Given this list of marker genes DST, MGP, CELSR1, AK5, ANPEP, DACH1, SSH3, NPY2R, IGFBP2, BST2, PDGFA, STC1, PPIP5K1, ACADSB (NCBI Gene Id 654185), ARMT1, PDZK1, HMGCS2, CELSR2, H2AC6, MYB, ZDHHC11, MAPT, ERBB4, CNN1, CA12, INPP4B, HBB, CRLF1, LTBP4, SERPINA5, SLC39A6, RABGAP1, SYMPK, LAMB3, GRP, KCTD2, FGF2, IGSF1, KDM4B, CPB1, FRMD4A, DNAJC12, WIF1 (WNT inhibitory factor 1), HBA1, ESR1, ANKH, IGF1R, PLAT, NEDD4L, CHI3L1 (chitinase 3 like 1, NCBI Gene Id 7836), COL4A5, KLK10, KRT5, TAPT1, SEZ6L2, FBXO2, ALDH4A1, CACNA1D, SLC27A6, CDK10, LGALS4, MPPED2 (NCBI Gene Id 744), WNT5A, PEX6, KRT6B, IFT140, DKK3, LTF (lactotransferrin), WFDC2, ACSM1, PTN, FRZB, MSX2, PKP1, SDC4, GFRA1, TRA2A, CYP1A1, GSTT1, TIMM44, CD59, RPL29P17 (NCBI Gene Id 729105), SLC25A37, KRT17, MYLK, ECE1, ARHGEF5, CLEC3B, CAPN3, TPM2, CLMN, EREG, GOLGA2P5, STC2, SYT17, FABP7, RABEP1, FLNB, AZGP1, TMEM101, CCDC170, TESC, NPY1R, SYNM, NQO1, EXOC7, EDN3, IL17RB, PPP1R3C, FGFR3, MATN2, OXTR (NCBI Gene Id 5021), GATA3, PIK3R1 (NCBI Gene Id 5295), SERPINA3, MIA, GRIA2, UGT2B11 (NCBI Gene Id 10720), CYP4B1, TDRD12, SAA1, XYLT2, VTCN1, TF, CITED1 (Cbp/p300 interacting transactivator with Glu/Asp rich carboxy-terminal domain 1), ITGA7, DCT, LTBP3 (latent transforming growth factor beta binding protein 3), CD151, ITPR1, BMP5, SCUBE2, PGGHG, here is a description of the gene set: from publication Poola I, DeWitty RL, Marshalleck JJ, Bhatnagar R, Abraham J, Leffall LD (PMID 15864312) Breast cancer is the second leading cause of cancer death for women in the United States. In 2005, about 215,000 cases of invasive breast cancer (IBC) and 50,000 cases of ductal carcinoma in situ will be diagnosed and 40,000 women will die of IBC in the US. Yet there is presently no molecular marker that can be used to detect a precancerous state or identify which premalignant lesions will develop into invasive breast cancer. Here we report the gene expression analysis of atypical ductal hyperplastic tissues from patients with and without a history of breast cancer. We identify MMP-1 as a candidate marker that may be useful for identification of breast lesions that can develop into cancer. studied in species Homo sapiens Human Gene Set: POOLA_INVASIVE_BREAST_CANCER_DN Genes down-regulated in atypical ductal hyperplastic tissues from patients with (ADHC) breast cancer vs those without the cancer (ADH).